The following is a description of a gene set: Toll-like receptor signaling studied in species Mus musculus Mouse Gene Set: WP_TOLLLIKE_RECEPTOR_SIGNALING, and this is the list of marker genes: Mal, Myd88, Tlr4, Traf6 (TNF receptor-associated factor 6), Mapk14, Tbk1, Tlr2 (toll-like receptor 2), Ikbke, Irf3, Irak4, Nfkb2, Ikbkb, Mxd3, Nfkb1, Tlr3, Irak1, Irak3, Tab2 (NCBI Gene Id 68652), Ticam1, Irak2, Nr2c2, Ticam2, Eif2ak2, Traf3, Abi1, Map2k6, Casp8, Casp3, Ikbkg, Ralbp1, Chuk, Tirap